The following is a description of a gene set: Human Gene Set: GOBP_T_CELL_CYTOKINE_PRODUCTION Any process that contributes to cytokine production by a T cell. studied in species Homo sapiens, and this is the list of marker genes: IL1B, TRAF6, IL4, SASH3, LILRB4, HFE (homeostatic iron regulator), TRAF2 (TNF receptor associated factor 2), IL18, NLRP3, FOXP3, PRKCZ, CD55, DENND1B, TRPM4, ARID5A, CD7, CLC, SECTM1 (NCBI Gene Id 6398), ARG1, IL1R1, CD81 (NCBI Gene Id 975), IFNB1, GATA3, RSAD2, SMAD7, TBX21, SLAMF1, CCR2, HLA-A, TNFRSF1B, MALT1, FZD5, IL6, TNFSF4, B2M, IL18R1, MAP3K7, IFNA2, HLA-F, XCL1